Given this list of marker genes Tmod1 (tropomodulin 1), Tcap, Myh11, Ttn, Rap1gds1, Mybpc3, here is a description of the gene set: Mouse Gene Set: GOBP_MYOSIN_FILAMENT_ASSEMBLY species: Mus musculus The aggregation, arrangement and bonding together of a filament composed of myosin molecules.